The following is a description of a gene set: Human Gene Set: GSE2706_UNSTIM_VS_8H_R848_DC_DN from publication Napolitani G, Rinaldi A, Bertoni F, Sallusto F, Lanzavecchia A (PMID 15995707) studied in species Homo sapiens Toll like receptors (TLRs) sense microbial products and initiate adaptive immune responses by activating dendritic cells (DCs). Since pathogens may contain several agonists we asked whether different TLRs may synergize in DC activation. We report that in human and mouse DC TLR3 or TLR4 potently synergize with TLR7, TLR8 or TLR9 in the induction of selected cytokine genes. Upon synergistic stimulation, IL-12, IL-23 and Delta-4 are induced at levels 50-100 fold higher than those induced by optimal concentrations of single agonists, leading to enhanced and sustained TH1 polarizing capacity. Using microarray analysis we show that only 1.5% of the transcripts induced by single TLR agonists are synergistically regulated by combinations of TLR4 and TLR8 agonists. These results identify a combinatorial code by which DCs discriminate pathogens and provide (suggest) a rationale to design adjuvants for TH1 responses. Series_overall_design: 3 untreated, 3 treated with LPS at 2h, 3 treated with LPS at 8h, 3 treated with R848 at 2h, 3 treated with R848 at 8h, 3 treated with LPS + R848 at 2h, 3 treated with LPS + R848 at 8h Genes down-regulated in comparison of unstimulated dendritic cells (DC) at 0 h versus DCs stimulated with R848 for 8 h., and this is the list of marker genes: MAML2 (mastermind like transcriptional coactivator 2), TCAF2, CXCL5 (NCBI Gene Id 6374), RIGI, CXCL10, OR5I1, PMAIP1, PPP1R3A, INHBA, TNFAIP6, PLAT, TCF7L2, MAP3K8, BIRC3, ADA, UHRF1, HERC5, IL7, EDEM1, ZNF732, SH2D1B, DDX60L, BTG1, IFIT1, NABP1, PARP9, RAB30, FRMD3, PARP14, CD48, SLFN5, GADD45A, LTA, NFKB1, AK8, EIF2AK2, MIR155HG, FSD1L, STX11, FXYD6, WARS1, CYRIA, DGKH, SESN3 (sestrin 3), TMEM268, ISG20, DUSP4, STAT1, FEZ1, TNFAIP2, ARL4D, LILRB2, SLC9A7, GRHL1, GRASLND, ABTB2, RAPGEF2, IFI44, AFAP1L2, NCK2, ETV3, TNFAIP3, MCOLN2, ANKRD33B, HERC6, INSIG1, CD70, CXCL11, OSBPL3, EPSTI1, TINAGL1, NR4A3, MOXD1, SOCS3 (suppressor of cytokine signaling 3), USP18, AFDN, UGCG, STAT4, TNC, SLAMF1, ATP13A3, IFIH1, TNFRSF4 (TNF receptor superfamily member 4), SKIL, PTGIR (NCBI Gene Id 5739), CCL11, TTN, PSMA6, SIAH2, SAT1, IGSF3, ARHGAP24, SWAP70, NAMPT, FBN3, TRIM69, RGS1, PLXNC1, AEN, GPR157, IFI35, NFKBIZ, TNFAIP8, LILRA3, XAF1, BAZ1A, SMURF2, CMPK2, TNFRSF11B, HIVEP1, PIM2, SINHCAF (SIN3-HDAC complex associated factor), DESI1, RNF213, APOBEC3A, TMPRSS12, C17orf58 (NCBI Gene Id 284018), YAP1, CORO2B, CCL1, TRAF1, CRACD, MASTL, SSB, ZC3H12A, IL15, GADD45B (NCBI Gene Id 4616), TNFSF10, ISG15, CEP135, TDRD7, NANOS1, GPHB5, TNF, NMI, GPR137B, CCR7, GBP1, ARMCX3, ITGB8, SLC5A9, LAMB3, CYTIP, GUCY1B1, SIPA1L1, LILRA5, DNAJB7, SHROOM3, PHLDB3, COBLL1, IL6, LRRC77P, SOD2, STEAP1B, ROPN1B, IFIT2, SLC1A2, MACC1, OAS2, EBI3, NLRC5, MARCKSL1, RASGRP1, IFIT3, LYRM1, TNFSF15, RFTN1, IL36G, NEURL3, PSD3, CASP7, SLAMF7, DUSP5, SNHG15, REL, BRWD3, TXN, CD274, THBS1, RELB, C15orf48, SOX11, IQCG, HYMAI, PLAGL1, CRLF2, LAMB2P1, G0S2, BATF, BTG3, MGLL, PTGER4, IFI6, TFPI, SAMD9L, MMP7, IL1B